The following is a description of a gene set: While in humans excess methionine is converted to homocysteine, homocysteine and its transsulfuration product cysteine can be degraded to several end products, two of which, taurine and hydrogen sulfide, have uses in other biological processes (Stipanuk & Ueki 2011). Reactome Pathway: Degradation of cysteine and homocysteine part of: Sulfur amino acid metabolism studied in species Homo sapiens, and this is the list of marker genes: CDO1, ADO, TST, SLC25A10, TXN2, GADL1, FMO1, ETHE1, CSAD (cysteine sulfinic acid decarboxylase), MPST, GOT2, TSTD1, CTH, SQOR, SUOX